Given this list of marker genes Npm1, Rrp7a, Wrn, Tert, Rpf2, Nop53, Mcrs1, Cacnb4, Utp25, Polr1a, Nol8, Ran, Nmd3, Pinx1, Nvl, Glul, Rrs1, Cdkn2a, here is a description of the gene set: Mouse Gene Set: GOBP_PROTEIN_LOCALIZATION_TO_NUCLEOLUS A process in which a protein is transported to, or maintained in, a location within a nucleolus. studied in species Mus musculus